The following is a description of a gene set: Any process that modulates the frequency, rate, or extent of CD4-positive, alpha-beta T cell differentiation. Mouse Gene Set: GOBP_REGULATION_OF_CD4_POSITIVE_ALPHA_BETA_T_CELL_DIFFERENTIATION species: Mus musculus, and this is the list of marker genes: Cbfb, Runx3, Nckap1l, Ep300, Ripk2 (NCBI Gene Id 70170), Gimap5, Shb, H2-Ea, Foxp3, Anxa1, Rc3h2, Tnfsf4, Il18, Il4, Tnfsf18, Gimap3, Loxl3, Cd69, Lgals1, Prkcz, Ccr7, Ccr6, Irf1, Rara, Jak3, Gata3, Opa1, Rc3h1, Socs1, Tgfb1, Brd2, Socs5, Il27, Zfp35, Il6, Kcnk18, Mir301, Ccr2, Malt1, Ccl20, Sh3rf1, Klhl25, Ifng, Il23a, Il4ra, Runx1, Sash3, Cd83, Ascl2, Brd4, Ccl19, Tbx21, Mir326, Smad7, Hmgb1, Pf4, Hlx, Nlrp3, Zbtb7b, Nfkbid, Zc3h12a, Il2rg, Il2, Bcl6, Nfkbiz